Given this list of marker genes UGT2B7, RARA, LRAT, FABP5, UGT2B4, COQ9, RBP3, C8G, UGT1A8, NR2F2 (nuclear receptor subfamily 2 group F member 2), CRABP2, CYP26C1, RBP7, CYP27C1, ADH4, CRABP1, LCN12, RBP5, STRA6, RBP2 (retinol binding protein 2), RLBP1, UGT1A6, ALDH1A2, UGT1A4, CYP26B1, CYP26A1, UGT1A10, OPN3, RBP4, UGT1A1, UGT2B15, ADH7, UGT2B17, OPN4, RXRA, OPN5, SERPINA5, IGF2R, UGT1A7, ABCA4, CYP2W1, UGT1A3, RBP1, RHO, PTGDS, UGT1A9, here is a description of the gene set: studied in species Homo sapiens Human Gene Set: GOMF_ISOPRENOID_BINDING Binding to an isoprenoid compound, isoprene (2-methylbuta-1,3-diene) or compounds containing or derived from linked isoprene (3-methyl-2-butenylene) residues.